Given this list of marker genes LPCAT3, ABCG8, LEP, APOA4, APOA1, APOA2, ABCG5, CYP8B1, ENPP7, here is a description of the gene set: Any process that modulates the frequency, rate or extent of absorption of cholesterol into the blood, and the exclusion of other sterols from absorption. studied in species Homo sapiens Human Gene Set: GOBP_REGULATION_OF_INTESTINAL_CHOLESTEROL_ABSORPTION